Given this list of marker genes LIG4, DNTT, POLM, DCLRE1C, CSNK2A1, XRCC4, XRCC5, PNKP (NCBI Gene Id 11284), APTX, PRKDC, APLF, NHEJ1, POLL, CSNK2B, CSNK2A2, XRCC6, here is a description of the gene set: from publication Schaefer CF, Anthony K, Krupa S, Buchoff J, Day M, Hannay T, Buetow KH (PMID 18832364) Human Gene Set: PID_DNA_PK_PATHWAY DNA-PK pathway in nonhomologous end joining species: Homo sapiens